Given this list of marker genes TGFB3, COG1, CD96, CDK10, GJA5, TAF4, KDM5B, DIS3L2, BBS2, RERE, TMEM147, MTOR, DHX30, EP300, MARS2, TBL1XR1, STEEP1, ADNP, DHX9, KIF26A, AFF3, TPR, TRRAP, QRICH1, ZNF148, DYRK1A, PIGQ, STAG2, TMEM94, POLR3A, MED13, CCBE1, DHPS, UBE3B, TTI1, SATB2, SMPD4, SMG8, THOC6, PIGB, NUP107, LEMD2, EBF3, PUS7, HNRNPC (NCBI Gene Id 3183), NSUN2, AASS, NIPBL, AP3D1, ORC4, ZMIZ1, FLCN, FBXO11, GAD1, TASP1, ATP9A, RAI1, MAPK1, SRRM2, SMC1A, GOLGA2, EXOC2, PIGN, CERT1, FOXG1, AHDC1, CLIC2 (NCBI Gene Id 1193), FLNA (NCBI Gene Id 8272), KDM6A, ADAMTSL2, RPL10, KIF7, THSD1, CSNK2B, UGDH, SMC3, FBXL4, DYM, DPM1, IFT140, ZNF292, GNE, NALCN, SEC23A (NCBI Gene Id 353367), MAN1B1, ANKRD11, UNC80, MKS1, SPTBN1, MAB21L1, ATP6V0A2, TUBGCP2, CDC42, AP3B1, CEP295, EBP, TRPS1, MEIS2, CTNNB1, COG7, JARID2, MSL3, RAP1GDS1, CASK, IFIH1, CHD8, CNTNAP2, SMARCA2, ANKRD17, TBX1, CDH2, NOTCH3 (NCBI Gene Id 791), SIN3A, PTPRF, POLR3GL, PLAA, SLC25A24, SYT1, SATB1, RHOBTB2, TRIM8, FLI1, WDR35, WDR37, PGM2L1, PUF60, ABL1, RAP1B, PPP2R3C, GJA8, THUMPD1, FAR1, FBN1, ZFX, CDK13, KDM5C, PRDX1, PKDCC, COL3A1, HNRNPU, CRKL, IRX5, RECQL (NCBI Gene Id 5965), ATP6V1A, PACS1, RTTN, PRIM1, USP9X, KDM5A, ATP6V1E1, ALG9, IGF1R, CDC42BPB, SUMF1, KIF15, WBP4, ZBTB18, SON, ZNF699 (zinc finger protein 699), ATG7, HOXB1 (homeobox B1), SPOP, PAX3, ACER3, RNU4-2, H4C5, SLC45A1, H3-3A, EXOSC1, CREBBP, PIK3CA, MED12, ZPR1, KMT2D, PIGU, WDR19, TRIP12, PYCR2, FRA10AC1, ADSL, ASH1L, MMACHC, PPP1CB, DDX6, RAD21, SETD5, MID1, ZC4H2 (NCBI Gene Id 7493), SMS, TRAPPC9, ESAM, BCR, MYOD1, CANT1, MAF, here is a description of the gene set: Human Gene Set: HP_SMOOTH_PHILTRUM species: Homo sapiens Smooth philtrum Flat skin surface, with no ridge formation in the central region of the upper lip between the nasal base and upper vermilion border.